Given this list of marker genes Psma1, Psma7, Tuba8, Psmc2, Emd, Ube2s, Tubb4b, B9d2, Ppp2r5a, Smc3, Vrk1, Ube2c, Chmp2b, Ube2e1, Psmc1 (protease (prosome, macropain) 26S subunit, ATPase 1), Psmd6, Psmc6, Cenpn, Nudc, Mis12, Kpnb1, Psma5 (proteasome subunit alpha 5), Psmd1 (proteasome (prosome, macropain) 26S subunit, non-ATPase, 1), Cdc26, Psmd12, Lbr, Tuba4a, Ndc80, Ppp2r5b, Tubb4a, Ndel1, Plk1, Anapc10, Zwilch, Tuba1a, Dynll1, Nup155, Cenpq, Tubb2b, Ube2d1, Hdac8, Vrk2, Nup205, Cenps, Anapc15 (NCBI Gene Id 75430), Dync1li2, Psmc3, Psma3, Spc24 (SPC24, NDC80 kinetochore complex component, homolog (S. cerevisiae)), Ska1, Lmna, Clasp1, Ubb (NCBI Gene Id 22187), Cenpt, Nde1, Ccnb1, Sumo1, Psmc4, Tubb6, Cdk1, Nup133, Ist1, Ppp2r5d, Xpo1, Seh1l, Psmb5, Kntc1, Tuba3b, Cenpm, Psma2, Mad1l1, Stag1, Kif2b, Lmnb1, Mad2l1, Psmd13, Chmp2a, Cdc23, Ppp2r1b, Anapc7, Nup85, Cenpa, Ndc1, Ran, Psmb6, Ppp2r2a (NCBI Gene Id 71978), Itgb3bp, Tuba1c, Psmd7, Cc2d1b, Rps27a, Psmb7, Cenpu, Psmc5, Aurkb, Psma6, Nup93, Rad21, Ankle2, Kif2c, Tubal3, Cenpe, Tuba1b, Psmb4, Psma4, Anapc2, here is a description of the gene set: Reactome Pathway: Mitotic Anaphase This event has been computationally inferred from an event that has been demonstrated in another species.<p>The inference is based on the homology mapping from PANTHER. Briefly, reactions for which all involved PhysicalEntities (in input, output and catalyst) have a mapped orthologue/paralogue (for complexes at least 75% of components must have a mapping) are inferred to the other species. part of: Mitotic Metaphase and Anaphase species: Mus musculus electronically inferred by orthology from the curated human pathway